The following is a description of a gene set: from publication Watford WT, Hissong BD, Durant LR, Yamane H, Muul LM, Kanno Y, Tato CM, Ramos HL, Berger AE, Mielke L, Pesu M, Solomon B, Frucht DM, Paul WE, Sher A, Jankovic D, Tsichlis PN, O'Shea JJ (PMID 19001140) Genes up-regulated in peripheral blood monocytes (PBMC): control versus IL-12 stimulation. species: Homo sapiens The cytokine interleukin-12 (IL-12) is known to play a central role in adaptive and innate immunity. We employed microarray analysis of IL-12 induced gene expression to provide further insights into its effects on immune response. Human Gene Set: GSE12839_CTRL_VS_IL12_TREATED_PBMC_UP, and this is the list of marker genes: ECT2, TRIM24, GEMIN4, UNC5B, ORC4, GARIN5B, PCGF5, SMPD4, MFSD2A, SAV1, PERP, RPRM, COBLL1, UBE2L6 (NCBI Gene Id 9246), ZGLP1, ANO3, HYLS1, EGFL6, LIF, DDOST, UTP18, SLC25A19, NME7, LMAN1, TFG, ERRFI1, PRIM2, LAMC1, ESCO2, PANK1, COX6B2 (cytochrome c oxidase subunit 6B2), DUSP14, ASNS, CCDC50 (coiled-coil domain containing 50, NCBI Gene Id 338335), AOC3, ZCCHC8, MTFMT, TENT4A, TPSB2, ACSF3, TNNT1, NIBAN2, VAMP7, TADA2A, PCDHB10, ANLN, UQCC1, ST3GAL4, CPT1A, ERGIC1, FAF2, CPE, ABHD10, PIK3C2G, SLC3A2 (solute carrier family 3 member 2), ETFDH (electron transfer flavoprotein dehydrogenase), RBL1, FBXW7, CLNS1A, MPHOSPH6, SLC25A33, TMEM209, ENDOD1, LRRFIP2, FAM43A, CLSTN1, CLTB, CASQ1, MRPL16, MEA1, SUMO3, TCEAL8, ADCYAP1, PEX11A, HTR3B, GPN1, PHLDA3, LRRC57, FSCN1, TPD52L1, TSPAN15, FIGNL1, GNG2, CRYAA, PEX2, GLB1, RPL5, CSN2, SHCBP1 (NCBI Gene Id 79801), LRRC28, FOXI1, GAB2, PPP2R3C, CRLS1, MRPS18B, GFAP, ALG8, LANCL2, BEX1, NECTIN3, DBF4, SNX1, USP44, NGRN, BRCA1, SARNP, AXL, GORASP2, LGI2, SND1, ADGRG2, MRTO4, RAD51B, CMPK1, FLG2, ECM1, TTC21B, SSR2, ATAD1, HAUS2, HORMAD2, TBC1D24, PSMA5, HIC1, NELL1, CIT, KCNJ4 (NCBI Gene Id 3761), H4C4, UQCRQ, GAPDH, SMYD2, SPATA7, EXOC3, VBP1, BLM, SEC23B, MCM8, TIAM1, NFE2L1, H2AC8 (H2A clustered histone 8), GGH (NCBI Gene Id 8836), MIF, IFI44, CRIP2, PDP1, DOC2B, NUP155, GOLGA8A, TMED2 (transmembrane p24 trafficking protein 2)